The following is a description of a gene set: Any process that increases the rate, frequency, or extent of the spindle checkpoint, a cell cycle checkpoint that delays the metaphase/anaphase transition until the spindle is correctly assembled and oriented, and chromosomes are attached to the spindle. Human Gene Set: GOBP_POSITIVE_REGULATION_OF_SPINDLE_CHECKPOINT studied in species Homo sapiens, and this is the list of marker genes: BIRC5, XRCC3, MAD1L1, AURKB, MAD2L1, TPR, KNL1, DYNC1LI1, INCENP, NDC80, CDCA8, GEN1